The following is a description of a gene set: species: Homo sapiens Abnormal adipose tissue morphology An abnormality of adipose tissue, which is loose connective tissue composed of adipocytes. Human Gene Set: HP_ABNORMAL_ADIPOSE_TISSUE_MORPHOLOGY, and this is the list of marker genes: LMNB2, SEC23B, TMEM43, VPS4A, GNAS, GNB2, JPH2, ADAR, CDH23, PLIN1, FH, SKI, AGPAT2, MT-TK, PDE11A, KCNK9, MPLKIP, TNNT2, PRDM10, CRYAB, TRAPPC14, PHGDH, FHL2, ADAMTSL2, TTN (NCBI Gene Id 7847), NF2, HEPACAM, WRN, KRAS, ACTC1, LIPE, BAG5, MFN2, SPRED1, SDHC, AP2S1, DPAGT1, CDC73, ACTN2, PLAAT3, RNASEH2C (NCBI Gene Id 84153), CLMP, MYH6, ALMS1, MT-TQ, DSG2, ALG12, FLCN, RNF113A, ZSWIM6, ALX3, RAF1, SDHA, MSTO1, COL1A1, ANKRD1, KLLN, INSR, POLR3A, PSMB4, ENPP1, MT-TF, TAF1, POLD1, ALB, TRMT10A, VEZF1, FLNA, TP53, LMF1, BSCL2, MYSM1, ADA2, NEXN, ABCC6, TGFB1, MEN1, GNA11, ZMPSTE24, CARS1, PRKACA, GTF2E2 (NCBI Gene Id 2961), BLM, PTPN6, ERCC3, PPCS, CDKN2B, SMARCB1, IKBKG, NF1, DSP, MNX1, PSMG2, SDHB, TGFB3, FASLG, KIF11, KDM1A, TAF1A, MT-TS2, SYNE1, ACTB, POMC, MT-RNR1, BRAF, FUZ, OTULIN, NR3C1, SGCD, TAFAZZIN, LAMA4, PTF1A, CASP10, TXNRD2, LCK, CDKN1B, GTF2H5, CDKN1A, EMD, TOP3A, FHL1, BAG3, GET3, TBL1XR1, ERCC2, PORCN, INPP5K, FKTN, DDOST, CYP27B1, SPRTN, MT-TH, TYROBP, USP48, CDKN2C, VDR, LEMD3, PSMB8, PIK3CA, SAMHD1, SDHD, CSRP3, SLC29A3, GRM7, TNNC1, RPL10, ATP6V1A, PCYT1A, MYH7, SOX18 (NCBI Gene Id 54345), ALG9, TBXT, RNU7-1, ATRX, DNASE2, KCTD1, ATP6V1E1, RNASEH2B, ALG3, COL1A2, FUCA1, B4GALT7, BMPR1A, MT-ND5, H4C5, RBM20, KCNJ6, TNNI3, ABCC9, POMP (proteasome maturation protein), DOCK11, SYNE2, RBM28, AKT1, TWIST2, SERPINA1, ALX1, VCL (NCBI Gene Id 7414), IFIH1, RPL3L, AKT2, MT-TP, DES, GATAD1, COQ6, NAA10, ADAMTS2, ERCC4, PSEN2, ADRA2A, LMNA, TPM1, ERCC6, SLC2A2, USP8, LEMD2, PRDM16, PSEN1, BANF1 (NCBI Gene Id 8815), CCL2, LSM11, PDGFRB, ERCC8, FGFR1, MT-TL1, PLN, APC, PPARG, LZTR1, PRKAR1A, USF3, TREX1 (NCBI Gene Id 82474), LMOD2, G6PC3, CAP2, AARS1, DMD, ALG11, IGF1R, MEFV, ALG8, HAND2, CAVIN1, PTEN, MAD1L1, LDB3, PCSK1, TARS1, FBN1, SLC25A24, TCAP, VANGL2, COL3A1, FOS, MC4R, CAV1, FAS, MYBPC3, CIDEC, TREM2, PRIM1, MYPN, PIK3R1, TMPO, HAVCR2, PPP1R15B, MTX2, VANGL1, ARMC5, RNASEH2A, DOLK, PMM2, ATP6V0A2, CHCHD10, SCN5A